The following is a description of a gene set: Genes down-regulated in comparison of CD4 T cells treated with IL4 and anti-IL12 at 1.5 h versus those at 72 h. Human Gene Set: GSE17974_1.5H_VS_72H_IL4_AND_ANTI_IL12_ACT_CD4_TCELL_DN The aim of this dataset was to study in detail the transcription kinetics initiated by cytokine IL-4 in early differentiation of Th2 cells. from publication Elo LL, Järvenpää H, Tuomela S, Raghav S, Ahlfors H, Laurila K, Gupta B, Lund RJ, Tahvanainen J, Hawkins RD, Oresic M, Lähdesmäki H, Rasool O, Rao KV, Aittokallio T, Lahesmaa R (PMID 20620947) studied in species Homo sapiens, and this is the list of marker genes: FAM219B, SNAP47, NT5C3B, PSMB8, GRHPR, DHTKD1, ZFTRAF1, ZNF821, PIAS3, MTA3, OXSM, CNOT1, GINS3, SFN, LINC00472, CPNE2, ARPC1B, ZC3H6, MRPS31, FSD1, HOMER1, DLG5, ITPR3, INTS13, SKA3, PTGIS, RDH11, RAB7A, RDX, PHB1, LRRC1, POLD3, CARM1, ORC3 (NCBI Gene Id 23595), BAX, MAMDC4, DHX58, ANKZF1, GNGT2, FNTB, NUDCD3 (NudC domain containing 3), MAD2L2, MCRIP2, TNFRSF4, AKR7A2 (aldo-keto reductase family 7 member A2), ISCA2, ACAP1, GMDS (GDP-mannose 4,6-dehydratase), PM20D2, CBY1, RAB23, UCK2, TIMM13, HPDL, SIGLEC17P, PTAR1, ACADM, ACOX3, RNF5, ATP5MC3, ZNF589, GBP2, EIF3J-DT, DBI, FUCA2 (NCBI Gene Id 83934), HPS3, HIRIP3, BRI3BP, ATP6V1F, DUSP5P1, MRPS16, PIH1D1, PINLYP, DVL2, DPH5, THYN1, EYA3, RAB26, IFT70A, JAML, PEAK1, POLR3K, WDR76, IPO11, SBF2-AS1, ACLY, NFAT5, MAPKAPK3, ACAT1, IRF2 (interferon regulatory factor 2), PRDX4, CENPF, RCCD1, GATB, ZNF775, UHRF1, TRAPPC5, TMEM273, DHX32, NDUFAF1, ERG28, ATG7, DOCK7, ZNF232, FIGNL1, SQOR, DHPS, NHP2, HOOK3, TBC1D31, PCMT1, PSMB2, TCEAL3, JAKMIP2, IL10RB-DT, MRPS34, KTN1, NR1H3, PSMB10, DIAPH3, TRIP13, CDK2 (cyclin dependent kinase 2), ZNF692, MRPL11, DDB2, TMEM187, BCAT1, ABRAXAS1, ABHD10 (abhydrolase domain containing 10, depalmitoylase), NRM, FGGY, F8, TMEM120A, ARPC5, EEF1AKMT1, PUDP, HEXIM2, P4HA1, STC2, ALDH18A1, RABEPK, HSD17B8, C12orf75, ZSCAN30, RUVBL2, ACADVL, MYO1B, RPA4, VCL, ELOA-AS1, BRIP1, NAA38, B3GNTL1, PCBD1, CDYL, GALM, NHERF1, ETHE1, MRPS15, ANGPTL6, RAD51C, SLC25A20, SRI, MAGEF1, FAM120A (family with sequence similarity 120 member A), CDK5, ZNF343, POLA1, ATIC, ARAP3, NCAPD3, TROAP, SH2D3C, NSD2, CENPM (NCBI Gene Id 79019), HMGB3, IL10RB, PAM (NCBI Gene Id 5066), CZIB, PDE6D, CENPI, SUV39H2, TXN2, DDAH2, PNPLA3, POLQ, CTNNAL1, MPZL2, HAUS4, ASF1B, ANXA4, PARVB, STYXL1, TWF2, PIMREG, TBL1XR1, HLTF, STX10, TRAF2